The following is a description of a gene set: studied in species Homo sapiens Mouse Gene Set: LIU_OVARIAN_CANCER_TUMORS_AND_XENOGRAFTS_XDGS_DN Genes differentially expressed between PDX and donor tumor samples from nine ovarian cancer patients. from publication Liu Y, Chanana P, Davila JI, Hou X, Zanfagnin V, McGehee CD, Goode EL, Polley EC, Haluska P, Weroha SJ, Wang C (PMID 31004097) A bioinformatics pipeline to separate donor tumor and mouse stroma transcriptome profiles was devised and tested. To examine the molecular fidelity of PDX versus donor tumors, the authors compared mRNA differences between paired PDX-donor tumors from nine ovarian cancer patients., and this is the list of marker genes: Gfpt2, Fermt3, Rac2, Lcp1, Dhrs9, Pou2af1, Scg2, Irag2, Hhipl1, Ccbe1, Fbxo32, Dok2, Dock8, Trem2, Fam83b, Sfrp2, Prdm6, Maob, Apoc1, Olfml3, Vwa5a, Il6, Fxyd5, Chit1, Tnfsf10, Col12a1, Asph (NCBI Gene Id 97379), Nlrc3, Cdo1, Mrc2, Apoc4, Cthrc1, Gadd45b, Rab27b, Palld, H2-Ea, Pthlh, Robo4, Dpyd, Hecw2, Robo2 (roundabout guidance receptor 2), Itgbl1, Rarb, Mndal, Sla, Lrrc8c, Mgll, C1qb (complement component 1, q subcomponent, beta polypeptide), Cd2, Ebf1, Hey1, Cd274, Mrgprf (MAS-related GPR, member F), Tgfb1i1, Igkv18-36, Il1rn, Col5a1, Prkacb, Il2ra, C2, Tpbg, Moxd1, Gsdmc3, Col11a1, Snca, Mlkl, Tlr2, Plaur, Slc11a1, Dpysl4, Emb, Nr4a3, Anxa6, Vamp5 (vesicle-associated membrane protein 5), Itgam, Gzmk, Tek, Fgl2, Rcn3, Fam89a, Vgll3, Chsy3, Jaml, Sstr1 (somatostatin receptor 1), Pitx2, Clec11a, Tafa2, Setd7, Il1b, Depp1, Aqp9, Pdzd4, Junb, Lcp2, Itga2, Rgs2, Fas, Tpst2, Medag (NCBI Gene Id 70717), Vcan, Lgals2, Agap2, Rhoj, Spart, Acta2, Enpep, Col6a6, Egr3, Heyl (hairy/enhancer-of-split related with YRPW motif-like), Wfdc21, Thbd, Fgr, Saa1, Cpe, Pde7b, Emcn, Fkbp7, Amph, Bmp4, Hoxc12, Jam3, Lamp5, Bgn, Mmp13, Hsd11b1 (hydroxysteroid 11-beta dehydrogenase 1), Lama4, Eps8, Fabp4, Pcolce, Pde1b, Cimap1b, Kcna6, Akt3, Tfpi, Pcolce2, Pdlim5 (NCBI Gene Id 99766), Btk, Myo1f, Slamf8, Scn7a, Il2rg, Cyth4, Chst2, Qpct, Vnn1, Adgre5, Nrxn2, Ppm1l, Srgn, Fyb1, Serpinb2, Lrrc55, Pkib, Lyz1, Spp1, Cnr1, Myocd, S100a8, Atp2a3, Npy1r (NCBI Gene Id 18166), Pid1, Arhgap9, Timp2, Slc46a3, Tgfbi, Cped1, Kcnd2, Rasgrf2, Socs3, mt-Tm, Tmem98, Serpine1, Elovl2, Iffo1, Nrp1, Ifit2, Fam171b, Inhba, Igll1, Cxcl13, Clec4e, Col6a3, Gjb2, H2-DMa, Plat, Aplnr, Gpr4, Lgals9, Hp, Slc16a7, Aff3, Mfng, Ccdc152, Olr1, Arsi, Lama2, Gata6, Bend4, Cd200, Il18r1, Camk4, Dchs1, Adh1, Tnfrsf11b, Stk17b, Cmah, Fcer1g, Zcchc24, Sgcd, Piezo2, Gpr68, Fosb, Fpr3, Mmrn2, Pirb, Pamr1, Dram1, Bend6, Tnfaip6, Hoxd10, Dio2 (deiodinase, iodothyronine, type II), Prox1, Cd180, Stom, Irf8, Dynlt3, Nipal2, Nrros, Tagln (transgelin), Cd248, H2-Eb1, Cd34 (NCBI Gene Id 98592), Cd40, Slc38a5, Sfmbt2, Eng, Nrp2, Sulf1, Arrdc3, Ptpn22, Colec12, Gna15, Ccl8, Serpinb1a, Stard5, Pycard, Hhip, Nod2, Jak3, Myo1g, Gpnmb, Apbb1ip, Cacna1c, Tlr1, Frmd6, Pde2a, Ptprn2, Adcy4, Dchs2, Unc5c, Gpr85, Coro1a, Sds (serine dehydratase), Bin2 (bridging integrator 2), Derl3, Cyria, H2-DMb1, Mgp, Glrx, Scimp, Filip1l, Abca6, Alox5ap, Megf10, Kif17, Klf9, Jchain, C1qtnf1, Aoah, Syde1, Col3a1, Rps27l, Dtna, Actg2, Pros1, Lcn2, Rragd, Trbc2, Apod, Arhgap15, Sparc (secreted acidic cysteine rich glycoprotein), Cd68, Kcnk6, St3gal5, Necab1, Deptor, Tnfrsf18, Prkd1, Tnfrsf14, Pstpip1, Creb3l1, Lysmd2, Calb2, Hsd17b11, Notch4, Apoe, Vstm4, Ppp2r2b, Map1lc3a, Twist1, Dnajb4 (NCBI Gene Id 76019), Tiparp, Itgal, Gimap1, Ncf2, Hmcn1, Antxr2, Calcrl, Hs3st1, Inpp4b, Ramp2, Edil3, Fst, Plk3, Gimap6, Fat4, Spred1, Hapln1, Sgpp1, Axl, Lst1, Dlc1, Tg, Ramp3, Ifit3, Socs2, Efcc1, Htra1, Plpp4, Vsir, Edn3, Klf2, Itga11, Pdpn, Serpinf1, Rimbp2, Bmp6, Atp8a2, Gspt2, Atp10d (NCBI Gene Id 352970), Dock4, Cd14, Ighg2b, Elovl4, Slco2a1, Gask1b (golgi associated kinase 1B), Col6a1, Car2, Ptpn5, Zfp521, Clic6, Aif1, Sdc2, Manea, Ccr5, Epyc, Bcl2a1b, Iglc1, Grk5, Fmo3, Cx3cr1, Hcst, Lpxn, Mmp9, Arhgap10, Igha, C7, Wscd1, Cd52, Sidt1, Copz2, Omd, Ctbs, Grk3, Trabd2b, Ifngr1, Nckap1l, Nudt11, Ramp1, Arhgap18, Osbpl6, Ccl20 (C-C motif chemokine ligand 20), Ighv1-54, Poglut2, I830077J02Rik, Gsdme, Lrrc4b, Lair1, Cldn11, Adgrl4, Fcnb, Klhl6, Prcd, Tap1, Rcsd1, Gimap5, Lrrc25, Ehd2, Septin11, Arhgap20, Smarca2, Jak2, Ism1, Fam78a, Tbx18, F2r, Aox1, Dcn, Adamdec1, Hs3st3b1, C3ar1, Nfatc2, Dsel, Pmp22, Gm13889, Fzd1, Klhl4, Tmem154, Itga5, Cxcl11, Dhrs3, Was, Serpinb9, Snx20, C1qtnf6, Ccn5, Trpc6, Slc16a14, Igkv16-104, Clec5a, Slamf7, S100a9, Sfrp1, Lhfpl6, Fos, Rgl1, Card6, Mpeg1, Ero1b, Akr1c6, Il7, Plcb2, C2cd4b, Casp1, Igfbp7, Plek, Ccdc85a, Gstm1, Plvap, Sh3rf3, Olfm1, Ctsk, Cilp2 (NCBI Gene Id 68709), Folr2, Spata18, Wdr17, Matn3, Ch25h, Slc4a4, Gpr176, Podn, Hcls1, AA467197, Ankrd22, Slc2a13, Esam, Plau, Sema6b, Chn1, Pde3b, Klhdc7b, Cmklr2, Itpr2, Gatm, Serping1, Slc2a5, Itga8, Alox5, C1qc, Ptgis, Arl15, Fmo2, Cald1, Zfp36, Epha3, Spn (sialophorin), Rtn1, Pdzk1ip1, Itga4, Klhdc1, Ednra, Lck, Niban1, Eif2s3x, Tmem150c, Plekho2, Odad2, Nid1, Mctp1, Pls3, Ednrb, Ddr2, Tcim, Cxcr6, Ighv5-6, Igkv8-21, Sell, Cish, Nkg7, Cspg4, Lpl, Lhx9, Fkbp1a, Arhgap30, Dpp7, Lrrc15, Gata4, Psd3, Lox, Il18, Sirpa, Sp6, Tbx3, Csgalnact1, Hck, Frmd3, Pik3ap1, Nfasc, Adora2a, Pld1, Nalf1, Man1c1, Trps1, Nlrp3, Ppp2r2c, Gpsm3, Runx2, Thbs1, Kdr, Nid2, Rasgrp3, Rgs1, Miat, Slc18a2, Pdzrn4, C1ra, Igkv4-50, Apoc2, Alpk2, Satb2, Cilp, Gzma, Apol6, Nrk, Plcl1, Or2i1, Slitrk5, Dnajc12, Cd44, Sat1, Ogn, Rftn1, Ighg1, Ccdc69, Gdnf, Adamts7, Fndc4, Cd28, Slc37a2, Calhm6, Gbp5, Gli1, Sectm1a, Vsig4, Dock2, Galnt18, Dok6, Cyp7b1, Tmem200a, Col10a1, Adgrf5, Fpr1, Mcc, Rasgrp2, Enpp2, Ighg3, Pde5a, Steap4, Pck1, Flt3l, Timp3, Lat2, Ecm1, Cntn4, Fn1, BC049715, Irag1, Hspb8, Olfm4, Slitrk2, Tie1, Tmem273, Has2, Naaa, Emp3, Cd48, Map1b, Plod2, Hmox1, Cldn5, Fbn1, Spon2, Ptgs2, Lmo2, Procr, Gdf6, Csf3r, B3gnt9, Stk32b, Fcgr2b, Trim47, Slc7a7, Ighv3-6, Tgfa, Fli1, Ceacam2, Negr1, Plppr3, Klrg1, Tril, Tnfrsf4 (NCBI Gene Id 22163), Rerg, Slc1a6, Adgrb3, Apela, Mgl2, Calhm5, Foxf2, Mt2, Wipf1, Nlrp1a, Zfp469 (NCBI Gene Id 195209), C2cd4c, Btbd19, Col5a3, Arhgap24, Enox1, Thsd7b, Aspn, Tenm3, Fhl2, Cerkl (NCBI Gene Id 228094), Foxf1, Mtus1, Lum, Pear1, Prickle2, Shisa2, Pdcd1lg2, Tnfsf8 (tumor necrosis factor (ligand) superfamily, member 8), Adamts2, Grem1, Il15ra, Xylt1, Rasal3, Nnmt, Cd38, Kcnj8, Hlx, Tlr3, Cd86, Osm, Cfh, Col8a1, Cacna2d1, Rassf4, Serpina1e, Kynu, Lacc1, Efemp1, Phldb2 (pleckstrin homology like domain, family B, member 2), Chst7, Satb1, Tesc (NCBI Gene Id 80653), Il2rb, Tyrobp, Gng4, Arhgef6, Tacc1, Serpina3n, Jcad, Pdk4, Lrch2, Fez1, Igfbp4, P2ry1, Ldaf1, Lyl1, Lrrn3, Pla2g4c, Cdkn1a, Cd93, Cxcl17, Kcnt2, Abi3bp, Hand2, Slc47a1, Phlda1, Adamtsl1, Gfra1, Rhobtb3, Abca9, Rarres1, Cxcl14, Mmp12, Pdgfd, Cd79a, Pcsk6, Cdk14, Ptger2, Cyp1b1, Pcyt1b, Cntn1 (NCBI Gene Id 12805), Gulp1, Ptger3, Ifi205, Prrx1, Kcnmb1, Chst11, Rasip1, Mdfic (MyoD family inhibitor domain containing), Fibin, Dab2, Tmem255a, Adamts12, Thbs2, Pten, Ccr2, Zeb2, Anpep, Ppp3cc, Ighv5-17, Ly96, Ighv3-1, Irf1, Shc2, Pwwp3b, Ndn (necdin, MAGE family member), Hcar2, Galnt15, Adamtsl2, Atp8b4, Fgf7 (fibroblast growth factor 7), Syne1, Vit, Marchf3, C3, Tfec (NCBI Gene Id 21426), Eda2r, Cav1, Scube2, Sparcl1 (SPARC-like 1), Epsti1, Csmd1, Gab3, Sod3, Ssc5d, Sypl2, Plppr4, Enpp1, Snai2, Ecscr, 2510009E07Rik, Cd4, Micu3, Itgb2, B2m, Abi3, Fgd2, Il16, Cracr2a, Ms4a4a, Ostm1, Elfn1 (NCBI Gene Id 243312), Col8a2, Dusp2, Ampd3, Prdm1, Fcho2, Gbp7, Spock1, C4b, Pdgfrl, Samsn1, Pik3r5, Runx1, Man1a, Antxr1, Sgk1, Dgki, Ggt5, Fam13c, Ebi3, Tmem158, Stard13, Alkal2, Mfrp (membrane frizzled-related protein), A4galt, Eaf2, Slc16a6, Hnmt, Scg5, Cbln2, Evi2b, Skap2, Mrap2, Pde4b, Rgs5, Nr4a1, C1s2, Serpini1, Adamtsl4, Gmfg, Rarres2, Aoc3, Jazf1 (NCBI Gene Id 231986), Gbp2b, Reck (NCBI Gene Id 53614), Synpo, H2-D1, Il4ra, Ackr1, Tnfaip8l2, Vim, Cr1l, Tnfsf13b, Selenop, Gas6, F13a1, Esm1, Vwf, Laptm5, Ly86, Npr3, Tigit, Tymp, Lrrc17, Acp5, Cdc20b, Serpinb8, Celf2, Ccl12 (NCBI Gene Id 20293), Jph4, Bmp2, Cdh2, Smim3, Cd74, Gpr132, Gimap7, Dpysl2, Stard8, Siglece (sialic acid binding Ig-like lectin E), Mfap4, Tnfrsf1b, Ifi30, Egr2, Dpp4, Hspa12b, Birc3, Ptpn7, Myh11, Thy1, Fap, Plxdc1, Cd3e, Icam1, Etv1, Vwa1, Rcan2, Gpr84, Enam, Irak3, Dclk1, Pygo1, Plagl1, Sulf2, Ldb2, Stambpl1, Pla2g2d, Nkd2, Gja1, Dpt, Ptafr, Il10ra, Thsd1, Timp1, Cpne8, Fbln5, Cdh13, H19, Wdfy4, Dlk1, Tmem119 (NCBI Gene Id 231633), Rubcnl, Bcl2, Trem1, Tnfaip8l3, Snx10, Mxra8, Gng11, Lrrc32, Ntm, Rnase6, Bnc1, Sh2b3, Cybrd1, Snap25, Star, Kcns3, Ftl1, Glipr2, Cd302, Scn9a, Ccl11, Lmod1, Wfdc1, Man2a1, Adm, Fgd5, Ccnd2, Nlrc4, Slc7a2, Pcdh17, Cntnap1, Hk3, Prrg3, Sfxn3, Loxl2, Gpm6a, Ets1, Scin, Tll1, Pnma2, Pla2g2a (NCBI Gene Id 18780), H2-Aa, Ikzf1, Ecm2, Nlgn4l, 1110032F04Rik, Atrnl1, Syce1, Rbms3, Ttyh2 (tweety family member 2), Cdc42ep5, Slc24a3 (NCBI Gene Id 94249), Gucy1a2, Rras, Pou2f2, Ripor2, Tagap, Htr2b, Grik3, Arx, Prkg1, Kitl, Rasa3, Il3ra, Scarf2, Tshz1 (teashirt zinc finger family member 1), Mir100hg, Plxnc1, Csmd2, Mmp14, Zfp365, Dkk2, Samd9l, Col14a1, Slc40a1, Lsp1, Lpar5, Ccdc68, Cd69, Nefh, Itga1, Cd209a (NCBI Gene Id 170786), Ctss, Gas1, Spi1, Kcnk3, Cass4, Ccn2, Pla2g7, Igf1, Gm11837, Slc43a1, Nme5, Itih3 (inter-alpha trypsin inhibitor, heavy chain 3), Mmp11 (matrix metallopeptidase 11), Ighv2-2, Nap1l3, Tshz3, Cd96, Slitrk4, Hgf, Ubd, Olfml2b, Inpp5d, A2m, Aqp1, Amigo2, Sphk1, Tnfrsf9, Mme, Astn1, Cpne5, Angptl2, Slc16a2, Abca8b, Cst7, Prf1, Dact3, Upp1, Dkk3 (dickkopf WNT signaling pathway inhibitor 3), Mpp1, Gimap4, Lrrn4cl, Cebpd, Mmrn1, Il33, Fam81b, Adam8, Angpt2, Ldlrad4, Cd8a, Gnb4, Fcmr, Rtn4rl2, Vat1l, Nexn, Dipk2b, Hlf, Mmp19, Col4a1, Prex2, Heg1, Igkc, Epb41l3, Sh3bgrl, Me1, Hs6st2, Acvrl1, Ggta1, Fgf13, Gpr183, She, Chrna1, Tmem204, Scube1, Cavin1, Clec7a, Synpo2, Pced1b, Rgcc, Parm1, Ccn1, Cnrip1, Ccdc80, Tnfaip3, Kctd12, Tm6sf1, Ell2, Col16a1 (collagen, type XVI, alpha 1), Plcxd3 (phosphatidylinositol-specific phospholipase C, X domain containing 3), Cfi, Rab42, Meis3, Emilin1, Chn2, Nts, Sncaip, Cavin2, Maff, Ogfrl1, Tspan5, Slc9a9, Sema5b, Grap, Prkcb, Adam23, Il7r, Flt1, Inmt, Tmem215, G0s2, Gpx8, Dusp5, Cpa3, Eogt, Eln, Marco, Arhgef15, Tnfaip8, Siglec1, Sbspon, Papss2, Dll4, Nt5e, Gabrb3, Lhfpl2, Nptx2, Sult1c1, Ccn4, Kcna5, Lrp1, Rftn2, Adam22, Csf2rb, Rap1b, Tceal7, Cdh11, Cd300a, Rhob, Psmb10, Sfrp4 (secreted frizzled-related protein 4), Sash3, Csta1, Afap1l1, Ablim3, Ighv8-12, Ccl19, Ak5, Nr5a2, Pdgfra, Cytip, Gpr34, Basp1, Postn, Lyplal1, Nkx3-1, Galnt5, Rab3il1, Tmem26, Mmp1b, Ndnf, Adgra2, Zfhx4, Tmigd3, Lag3, Peg3, Msr1, Pappa, Pld4, Abcc3, Magel2 (NCBI Gene Id 27385), Msn, Slc2a3, Cfd, Bmerb1 (bMERB domain containing 1), Tmem176b, Scn1b, Kcnj2, Slc31a2, Wnt5a, Sema3c, Exoc3l, Ptprb, Igdcc4, Cavin3, Cxcl2, Lgals1, Gprin3 (NCBI Gene Id 77535), Itk, Gprasp1, Itm2b, Sox18, Bche (butyrylcholinesterase), Tlr4 (toll-like receptor 4), Meis2, Cxcl9, Itgax, Elmo1, Col1a2, Fgf1, Comp, Mn1, Foxl1, Sirpb1c, Emilin2, Mzb1, Wasf3, Hic1, Islr, Ptpro, Maf, Prss35, Ghr, Egr1, Csf1r, Kcnk13, H2-Ab1, Pde1a, Rora, Smoc2, Kcnd3, Eva1c, Svep1, Cacna2d4, Ltbp2, Rgs16, Mef2c, Nr3c1, Runx1t1, Nr1h4, Tbx15, Trpv2, Col2a1, Fbxl7, Dusp1, Gng2, Tbxas1, Spib, Nbl1, Uba7 (NCBI Gene Id 74153), Tlr6, Gpr137b, Selp, Sh2d3c, Jam2, Pkia, Septin4, Tpsb2, Selplg, Oscar, Esr1, Fam20a, Kcne4, Rassf2, Cmklr1, Ms4a6b, Ntrk2, Il15, Slit2, Ido1 (NCBI Gene Id 15930), Iglc4, Mt1, Fmo1, Steap2, Arhgap25, Chrd, Ptgds, Gucy1a1, Aebp1, AU021092, Osmr, C1qtnf7, Cadm3, Podnl1, Clmp, Apcdd1, Cybb, Stat4, Cys1, Fhod3, Adamts4, Msrb3, Gpr65, Bicc1, Mapre2, Pdlim3, Cd247, St8sia1, Dpysl3, Pon3, Sting1, Rab6a, Gimap8, Slco2b1, Adam12, Fam43a, Arhgap31 (NCBI Gene Id 80655), Col1a1, Gpc6, Ankrd44, H2-Oa, Slpi, Csf2ra, Ptprc, S1pr1, Tcf4, Pik3cg, Epas1 (endothelial PAS domain protein 1), Icam5, Tnfrsf8, Ccl21a, Pgr, Hbb-bs, Ccr1, Ighv1-5, Kank3, Mmp2, Pln, P2rx7, Cd163, Flt4, Rab8b, Gal3st4, Abcb1a (ATP-binding cassette, sub-family B member 1A), Vwc2, Tspan8, Erg, Ncf4, Scarf1, Cxcl12, Fkbp14, Flrt2, Apobec3, Camk2d, Meg3, Prdm8, Pag1, Ighv1-69, Samd5, Adap2, Arhgdib, Rhoh, Smpdl3a, Cdh5, Ube2ql1, Eif5a2, Npl, Clec4a3, Tcf21, Trpa1, Clvs1, Ptn, Tlr7, Rab31, Acsl5, Clec14a, Cadps, Bcl11b, Ighv1-85, Chgb, Prelp, Kcnab2, Msc, Gtsf1, Dapl1, Cacna1h, Gypc, Rgs7bp, Lin7a, Cpz, Tle4, Slc1a1 (solute carrier family 1 (neuronal/epithelial high affinity glutamate transporter, system Xag), member 1), Chi3l1, Hbegf, Ms4a7, Corin, Gem, Srpx2, C1qa, F5, Abcg2, Col6a2, Lipa, Lxn (NCBI Gene Id 17035), Klf6, Dock11, Cd36, Heph, Stx11, Tshz2, Nfam1, Rgs4 (NCBI Gene Id 19736), Cd53, Acan, Tnfrsf11a, Tmem86a, Gjb6, Ppp1r16b, Tdo2, Pcdh12, Nav3, Olfml1 (olfactomedin-like 1), Nlrc5, Tmod2, Fcgr1, Igsf6, Cygb, Cacna1g, Zeb1, Lrrk2, Clic4, Cntn3, Adamts10, Pla2r1, Cp, Wnt5b, Glt8d2, Selenom, Fndc1, Tlr8, Cyp27a1, Igkv4-57, Mmp16, Fcgr4, Psmb9, Zbtb16, Adcyap1r1, Lzts1, Dact1, Tmem176a, Hopx, Apobr, St8sia4, Marchf1, Mapk11, Hs3st3a1, Nr5a1, Hoxc6, Thsd7a, Ptpre, Ighv5-2, Fkbp5, Hba-a1, Myct1, Pi15, Slc16a3, P3h3, Abhd3, Tmem47, Irs1, Serpine2, Rbp7, Shox2, Havcr2, Itprip, Hycc1, Itpr1, Cxcl10, Crispld2, Sqor, Vcam1, Il6st, Lyve1, Pde10a, Parvg, Gm5150 (NCBI Gene Id 381484), Lamb1, Atp1b2, Bhlhe41, Sp140, Itm2a, Siglecg, Plscr4, Il21r, Itgb6, Cd84, C1qtnf5, C5ar1, Pdgfrb, Cd300e, Ighm, Fstl1, Zfpm2, Sucnr1, Apol8, Vsnl1, Tbc1d4, Bcl6b, Aldh1a3, Cox7a1, Htra3, Srpx, Cmtm3, Col15a1, Cfb, C9, Col5a2, Igkv15-103, Abcb4, Nupr1, Stab1, Ahr, Lpar6, Evi2a, Saa2, Dock10